The following is a description of a gene set: species: Homo sapiens Neighborhood of CASP4 Human Gene Set: GNF2_CASP4 Neighborhood of CASP4 caspase 4, apoptosis-related cysteine peptidase in the GNF2 expression compendium, and this is the list of marker genes: TCIRG1, CMTM6, SELL, ICAM3, GMIP, LAPTM5, ARPC3, TUT7, ACTR2 (actin related protein 2), STAT6, CASP4 (NCBI Gene Id 837), SH3BGRL3, DAZAP2 (NCBI Gene Id 9802), ELF4, HCLS1, IQGAP1, RIN3, GMFG, HSD17B11, ZFP36L2, HLA-B, B2M, WAS, PSTPIP1